The following is a description of a gene set: Mouse Gene Set: GOBP_REGULATION_OF_MONONUCLEAR_CELL_MIGRATION Any process that modulates the rate, frequency or extent of mononuclear cell migration. Mononuclear cell migration is the movement of a mononuclear cell within or between different tissues and organs of the body. studied in species Mus musculus, and this is the list of marker genes: Spn (sialophorin), Calr, Adam8, Adtrp, Emilin1, Adam17, Tgfb1, Bcr, Itga4, Cd81 (NCBI Gene Id 12520), Cd200r1 (NCBI Gene Id 57781), Slit2, Ccr1, Mtus1, Ccl12, Ecm1, Fpr-rs6, Csf1r, Mapk1, Tnfsf18, Abr, Apod, BC037156, Ccl3, Lyn, Akirin1, Spi1, Ccr7, Stk39, Cd99l2, Klrk1, Ptk2b, Csf1, Cxcl14, Xcl1, P4hb, Ccl2, Ccr1l1, Ccl20, Abl2, Wnk1, Grem1, Abl1, Adam10, Pycard, Madcam1, Ccl21d (C-C motif chemokine ligand 21D), Serpine1, Gpr15lg, Aire, Wnt5a, Il4, Selenok, Ccl7, Cnn2, Cmklr1, Cx3cl1, Hmgb1, Ccl1, Cd69, Ccl21e, Dock8, Itgb3, Mif, Tnfsf14, Ccr6, Ccl5, Ptk2, Tnfsf4, Coro1a, Slamf1, Gas6, Ccr2, Fpr-rs3, Gcsam, Wasl, Ripk3, Aif1, Rhoa, P2rx4, Trem1, Rarres2, Tmem102, Ccl21a, Dusp1 (dual specificity phosphatase 1), Cd9, Pdgfd, Lgmn, Crk, Tnfrsf14, Nedd9 (NCBI Gene Id 319669), Plcb1, Ager (NCBI Gene Id 11596), Cx3cr1, Ifnb1, Lgals3 (lectin, galactose binding, soluble 3), C1qbp, Padi2, Mdk, Spns2, C3ar1, Trpv4, Mmp14, Crkl, Mapk3, Mst1, Il34, Cyp19a1, Fadd, Hc, Nbl1, Cxcl12, Slamf8 (SLAM family member 8), Mospd2, Cd200, Ccl21f, Cxcl17, Thbs1, Akt1, Rtn4, Jam3, C5ar1, Mia3, Slc8b1, App, Msn, Ninj1, Defb25, Fpr-rs7, Il27ra, Ripor2, Mmp28, Pla2g7, Mstn, Lgals9, Stk10, Jam2, Fpr-rs4, Cxcl10, Lrch1, Stap1, S100a14, Il12a, P2ry12, Ascl2, Ptprj, Med23, Trem2, Ano6, Ccl21b, Cd47, Ccn3, Oxsr1, Fpr2, Creb3, Cxcl13